Given this list of marker genes HDC, TPM1, HPGDS, ANKRD27, CDC20, CCNB2, EZH2, HBG1, RGCC, CLEC11A, HBD, XK, KLF1 (NCBI Gene Id 8055), SERPINB2, CHEK1, CTSL, ICAM4, BLVRB, CPOX, CCL3, APOC1, PF4, MYH10, CEP55 (centrosomal protein 55), CA2, MCM5, TFR2, DLC1, TUBB6, CENPF, H1-2, PALM2AKAP2, PRKAR2B, PRC1, HBA1, HBB, IL1RN, RACGAP1, JUN, LMNA, SMC2, PPIF, MINPP1, KIF11, NUDT4, TOP2A, CELA2B, ITGA2B, ASF1A, ZWINT, BAZ1A, MELK, APOE, CDK1, AMMECR1, PCCB (NCBI Gene Id 5096), TPSAB1, KIF15, GINS1, ELP5, PKIG, DHFR, RRM2, PCLAF, APOBEC3B, CCL8, CDKN3, TUBB2A, SULT1A3, PRDX2, CENPU, CA1, PDLIM1, RHAG, TST, LAT, CD36, CCL20 (C-C motif chemokine ligand 20, NCBI Gene Id 6364), XIST, AQP3, MICAL2, MPST, SAC3D1, CCL5, CD38, NUSAP1, DLGAP5, SPTA1, H2AX, CASP3, ELOVL6 (ELOVL fatty acid elongase 6), SERPINE2, LEPR (NCBI Gene Id 3953), TK1, here is a description of the gene set: Quiescent and dividing hemopoietic stem cells (HSC) display marked differences in their ability to move between the peripheral circulation and the bone marrow. Specifically, long-term engraftment potential predominantly resides in the quiescent HSC subfraction, and G-CSF mobilization results in the preferential accumulation of quiescent HSC in the periphery. In contrast, stem cells from chronic myeloid leukemia (CML) patients display a constitutive presence in the circulation. To understand the molecular basis for this, we have used microarray technology to analyze the transcriptional differences between dividing and quiescent, normal, and CML-derived CD34+ cells. Our data show a remarkable transcriptional similarity between normal and CML dividing cells, suggesting that the effects of BCR-ABL on the CD34+ cell transcriptome are more limited than previously thought. In addition, we show that quiescent CML cells are more similar to their dividing counterparts than quiescent normal cells are to theirs. We also show these transcriptional differences to be reflected in the altered proliferative activity of normal and CML CD34+ cells. Of the most interest is that the major class of genes that is more abundant in the quiescent cells compared with the dividing cells encodes members of the chemokine family. We propose a role for chemokines expressed by quiescent HSC in the orchestration of CD34+ cell mobilization. Disclosure of potential conflicts of interest is found at the end of this article. from publication Graham SM, Vass JK, Holyoake TL, Graham GJ (PMID 17717066) Human Gene Set: GRAHAM_CML_QUIESCENT_VS_NORMAL_QUIESCENT_UP Genes up-regulated in quiescent (G0) CD34+ cells isolated from peripheral blood of CML (chronic myeloid leukemia) patients compared to the quiescent cells from normal donors. studied in species Homo sapiens